Given this list of marker genes Kcnq2, Itsn1, Zdhhc5, Tmem184b, Rfng, Iqsec2, Cadm3 (cell adhesion molecule 3), Serpina3k, Ermp1, Mprip, Mknk1, Slamf1, Ppargc1a, Psd3, Ulk1, Ddb1, Arhgef9, Thrb, Arhgap1, Map4, Adgre4, R3hdm2, Ctnnd1, Disp3, Dedd2, Eif2ak3, Rc3h2, Mtcl2, 1700102P08Rik, Rapgefl1, Nkain1, Rangrf, Deaf1, Kcnip3, Mpp2, Tmem127 (NCBI Gene Id 98915), Slc25a23 (solute carrier family 25 (mitochondrial carrier; phosphate carrier), member 23), Gas7 (growth arrest specific 7), Nav1, Vdac3, Trip6, P2ry13, Hcfc1r1, Gprc5b, Nfatc4, Tex11, Tnfsf12, Ptcd2, Brwd1, Scai, Nckap5, Cdr2l (NCBI Gene Id 237988), Nhsl2, Lhx3, Rnf38, Plxna1, Plekhm3, Ptpn6, Dact3, Frem1, Fam53c, Tmem191, Vipr2, Abl2, Cartpt, Csmd1, Lman2l, Tspan7, Kif3a, Sema4f, Tmem132b, Glt8d2, Gse1, Bbip1, Kpna6, Epha10 (NCBI Gene Id 545678), Lrrc71, Usp42, Nfasc, S100a16, Rps6kb1, Ccno, Krt75, Serpina3c, Arih2, Limd1, Polr3g, Ubfd1, here is a description of the gene set: from publication Chen Y, Wang X (PMID 31504780) Genes predicted to be targets of miRBase v22 microRNA mmu_miR_7226_5p in miRDB v6.0 with MirTarget v4 prediction scores > 80 (high confidence targets). studied in species Mus musculus Mouse Gene Set: MIR_7226_5P